Given this list of marker genes Fyn, Dnm3, Prnp, Homer1, Adora2a, Necab2, here is a description of the gene set: Binding to a type 5 metabotropic glutamate receptor. Mouse Gene Set: GOMF_TYPE_5_METABOTROPIC_GLUTAMATE_RECEPTOR_BINDING species: Mus musculus